The following is a description of a gene set: species: Homo sapiens from publication Gavish A, Tyler M, Greenwald AC, Hoefflin R, Simkin D, Tschernichovsky R, Galili Darnell N, Somech E, Barbolin C, Antman T, Kovarsky D, Barrett T, Gonzalez Castro LN, Halder D, Chanoch-Myers R, Laffy J, Mints M, Wider A, Tal R, Spitzer A, Hara T, Raitses-Gurevich M, Stossel C, Golan T, Tirosh A, Suvà ML, Puram SV, Tirosh I (PMID 37258682) Human Gene Set: GAVISH_3CA_METAPROGRAM_MACROPHAGES_MAC_2 In this study, an extensive analysis was conducted to define meta-programs (MPs) capturing intra-tumor heterogeneity across a spectrum of tumor types. The approach utilized non-negative matrix factorization (NMF) to analyze each cell type separately within individual tumor samples. This involved the analysis of malignant cells, macrophages, fibroblasts, endothelial cells, epithelial cells, T-cells, and B-cells. NMF was executed with varying parameter values (K=4, 5, 6, 7, 8, 9), thereby generating 39 programs for each cell type per sample. Each NMF program was summarized by the top genes based on NMF coefficients.\nRobust MPs were then delineated for each cell type using a set of stringent criteria, including recurrence within the same tumor, similarity to programs in other tumors, and non-redundancy within a tumor. Subsequently, these robust NMF programs were clustered (per cell type) based on Jaccard similarity, leading to the identification of MPs associated with each cell type.\nTo enhance the quality of the MPs, a refinement steps were undertaken, involving the removal of MPs suspected of reflecting low-quality data (with an overrepresentation of ribosomal proteins or mitochondrial-encoded genes), single-study inclusion, or similarity to miss-annotated cell types. Genes upregulated in subsets of cells of a given type within various tumors, and this is the list of marker genes: SERPINA1, FHL1, NMB (neuromedin B), IFI27, PPIC, TGM2, MCEMP1, FN1, PCOLCE2, CCL18, STXBP2, INHBA, LTA4H, SERPING1, ALOX5AP, AGRP, S100A13, CD52, PLAAT3, LGALS3BP, CYP27A1, FABP4 (NCBI Gene Id 2167), UBASH3B, RETN, HDDC2, TCF7L2, NUPR1, RBP4, PHLDA3, AKR1C3, AQP3, GCHFR, RND3, CES1, SCD, ACOT7, GPD1 (glycerol-3-phosphate dehydrogenase 1), TREM1 (NCBI Gene Id 54210), IGFBP2, PPARG, MARCO, MGST1, FAM89A, FBP1, PDLIM1, GYPC, LPL, ALDH2, VMO1